Given this list of marker genes DLG1, GRIK4, GRIK2, DLG4, NCALD, GRIK3, GRIK1, CALM1, GRIK5, DLG3, here is a description of the gene set: Kainate receptors are either Ca2+ permeable or impermeable depending on the composition of the receptor and the editing status of subunits GluR5 and GluR6 (GRIK1 and 2). part of: Activation of kainate receptors upon glutamate binding Reactome Pathway: Ionotropic activity of kainate receptors species: Homo sapiens